Given this list of marker genes Tbc1d5 (NCBI Gene Id 72238), Sort1, Snx3, Rcsd1, Rab7, M6pr, Igf2r, Slc11a2 (solute carrier family 11 (proton-coupled divalent metal ion transporters), member 2), Washc2, here is a description of the gene set: species: Mus musculus Binding to a retromer complex. Mouse Gene Set: GOMF_RETROMER_COMPLEX_BINDING